Given this list of marker genes MLH1, PMS2P6, MSH3, PMS2P5, MSH6, MLH3, PMS2P3, MSH2, PMS2P1, PMS1, PMS2, here is a description of the gene set: Any complex formed of proteins that act in mismatch repair. Human Gene Set: GOCC_MISMATCH_REPAIR_COMPLEX species: Homo sapiens